Given this list of marker genes ANO2, ANO6, TMPRSS2, ACE2, S, ANO8, ANO1, M, ANO9, 7a, 3a, ANO3, ANO5, ANO7, ANO4, FURIN, E, ANO10, N, SARS coronavirus, complete genome, here is a description of the gene set: Reactome Pathway: Induction of Cell-Cell Fusion Many enveloped viruses induce multinucleated cells (syncytia) in later stages of viral infection. The membrane fusion that drives these cell-cell fusion events are caused by the same machinery that underlies viral entry. The presence of infected syncytial pneumocytes in severe COVID-19 patients is well established. However, it is currently unclear if syncytia formation is also a feature of milder or asymptomatic SARS-CoV-2 infections. These syncytia are also thought to facilitate replication and evasion of the host immune response (for a recent review on Spike-mediated fusion and syncytia formation see Rajah et al, 2022). Experiments that utilize co-cultures of human cells expressing the receptor ACE2 with cells expressing SARS-CoV-2 spike protein, result in synapse-like intercellular contacts that initiate cell-cell fusion, producing syncytia resembling those we identify in lungs of COVID-19 patients. Studies on SARS-CoV-2 identified similar syncytia. Formation of the ACE2/spike protein complex drives fusion events that proceed from finger-like projections, forming synapses between cells to development of a fusion pore and subsequent membrane fusion. Notably cleaving the spike protein into S1 and S2 sub-fragments appears to increase the probability of S1/ACE2 fusion.<br>The Alpha, Beta, and Delta variants of SARS-CoV-2 display enhanced syncytia formation. An additional phenomenon with SARS-CoV-2 syncytia is their targeting of lymphocytes for internalization and cell-in-cell mediated elimination, potentially contributing to lymphopenia and pathogenesis in COVID-19 patients. species: Homo sapiens part of: Late SARS-CoV-2 Infection Events